Given this list of marker genes PSMA1, PSMB3, PSMC6, PSMD14, PSMD2, PSMB4, PSMC2, ODC1, PSMC1, PSMC5, OAZ2, OAZ1, SEM1, PSMD3, PSMB5, NQO1, PSMA5, OAZ3, PSMA4, PSMD7, PSMA2, AZIN1, PSMB1, PSMC4, PSMB7, PSMD12, PSMD8, PSMA6, PSMD1, PSMC3, ADRM1, PSMB2 (proteasome 20S subunit beta 2), PSMD6, PSMB6, PSMD13, PSMA7 (proteasome 20S subunit alpha 7), PSMA3, PSMD11, here is a description of the gene set: Human Gene Set: REACTOME_REGULATION_OF_ORNITHINE_DECARBOXYLASE_ODC Regulation of ornithine decarboxylase (ODC) species: Homo sapiens